The following is a description of a gene set: species: Homo sapiens The appearance of interleukin-13 due to biosynthesis or secretion following a cellular stimulus, resulting in an increase in its intracellular or extracellular levels. Human Gene Set: GOBP_INTERLEUKIN_13_PRODUCTION, and this is the list of marker genes: IFNA2, IL17RA, TSLP, LGALS9, LILRA5, ARG2, TNFRSF21, SPHK2, GATA3, PRKCZ, IRF4 (NCBI Gene Id 4592), HLA-E, IL18, IL1RAP, TNFSF4 (NCBI Gene Id 7292), IL33, IL4, SCGB1A1, LEF1, IL17RB, RARA, IFNL1